Given this list of marker genes SEMA3F, PLSCR1, SEPSECS, SSMEM1, TYR, NQO1, LEKR1, PTGFR, GEM, MAPK6, FUT9, ANKRD13C, GPR156, ADAMTS3 (NCBI Gene Id 9508), DHFR, MAGEL2, PUM1, RING1, TENT4B, PDE1A, PIK3CB, SEC24B, AMMECR1L, APBA1 (NCBI Gene Id 320), RAP2C, ZDHHC21, RERE, EIF4E, PPARG, SGIP1, KIF21A, RPGRIP1L, SPRY3, LMO7, B4GALT6, PUS10, CD2AP, ATXN1L, MLLT3, DMD, ZDHHC9, SNRPB2, RAB11A, HDAC2, SHPRH, DEPDC1, PPP4R1, here is a description of the gene set: Genes predicted to be targets of miRBase v22 microRNA hsa-miR-10397-3p in miRDB v6.0 with MirTarget v4 prediction scores > 80 (high confidence targets). from publication Chen Y, Wang X (PMID 31504780) Human Gene Set: MIR10397_3P studied in species Homo sapiens